The following is a description of a gene set: studied in species Homo sapiens Human Gene Set: HP_SLOPING_FOREHEAD Sloping forehead Inclination of the anterior surface of the forehead from the vertical more than two standard deviations above the mean (objective); or apparently excessive posterior sloping of the forehead in a lateral view., and this is the list of marker genes: CENPE, SEPSECS, FANCA, PIGQ (phosphatidylinositol glycan anchor biosynthesis class Q), ASNS, PAK3, LTBP4, TSEN54, SCN1B, ANKLE2, SASS6 (SAS-6 centriolar assembly protein), RNU4-2, MCM7, FANCL, NEUROD2, GNAO1, ATR, TSEN2, CDK5RAP2, MKS1, CEP295, SLC25A22, RFWD3, PCDHGC4, STAG2, GPKOW, ACER3, NSUN2, KATNB1, TXNDC15, KCNA1, CRELD1, MCPH1, PIGP, EMG1, PSAT1, SLX4, CEP57, CNOT1, RNU4ATAC, SETBP1, RAD51, OSGEP, NUP107, METTL5, TCTN3, DYNC1I2, BRCA2, CSPP1, CIT, XRCC2, PCNT, BRCA1, ARX, RUNX2, PALB2, ZNF526, CEP63, KAT6B, MAD2L2, SMPD4, FANCI, SLC32A1, DDX11, PNKP, B9D1, FANCF, NFIX, TCTN2, STAMBP, FKRP, COPB2, OCLN, TRIP13, NDE1, RBM10 (NCBI Gene Id 8241), TMEM107, TRAPPC14, SCN2A, BUB3, TUBGCP2, FANCE, GLI3, FKBP14, COG4, RAD51C, FANCG, WDR62, TRIM8, QARS1, B9D2, PLK4, KNL1, XRCC4, ZNF335, GRM7, TTI2, KIFBP, KIF14, WDR73, NCAPD3, FANCD2, ERCC6, SARS1, CC2D2A, PYCR2, NHEJ1, TMEM67, VPS33B, EXOSC5, FANCM, PHGDH, FKTN, EIF2S3, TBCK, ZIC2, TRAPPC10, INTS11, STIL, KIF11, CTSD, VARS1, TMEM231, C2CD3, SLC25A19, MFSD2A, TUBGCP6, PARS2, TAF13, ERCC4, CEP152, CDKL5, PUM1, TSEN34, DMXL2, PAH, ASPM, UBE2T, CDK6, FANCB, TRIP12, TCTN1, RPGRIP1L, CAMK2B, TUBGCP4, MGP, WLS, VIPAS39, TMEM216, KIF7, PHC1, CEP290, BUB1B, POMT2, FANCC, BRIP1, RRP7A, RTTN, EXOC2, IL11RA, NUP37, CEP135, BUB1, RPGRIP1, LARGE1, TMEM237, GRIN1, SC5D, ASXL3, CCDC88A, TSEN15, NBN (nibrin, NCBI Gene Id 4683), WARS1, PRUNE1, CASK, RBBP8 (NCBI Gene Id 5932), RELN, SIK1, POMT1, NCAPD2, LIG4 (DNA ligase 4), CPT2, PHF8, UGP2, NCAPH, COASY, UFC1, ADAT3 (NCBI Gene Id 113179)